The following is a description of a gene set: Human Gene Set: REACTOME_RESOLUTION_OF_D_LOOP_STRUCTURES_THROUGH_SYNTHESIS_DEPENDENT_STRAND_ANNEALING_SDSA Resolution of D-loop Structures through Synthesis-Dependent Strand Annealing (SDSA) species: Homo sapiens, and this is the list of marker genes: BRCA1, SEM1, BRCA2, RAD51C, NBN (NCBI Gene Id 4683), BLM, TOP3A, ATM, XRCC2, RTEL1, RAD51, DNA2, RMI1, RBBP8, BARD1, BRIP1, RAD50, PALB2, EXO1 (NCBI Gene Id 9156), WRN, RAD51AP1, RMI2, RAD51B, MRE11, XRCC3, KAT5, RAD51D